The following is a description of a gene set: A process that is carried out at the cellular level which results in the assembly, arrangement of constituent parts, or disassembly of cytoskeletal structures comprising neurofilaments and their associated proteins. species: Mus musculus Mouse Gene Set: GOBP_NEUROFILAMENT_CYTOSKELETON_ORGANIZATION, and this is the list of marker genes: Ndel1, Arhgef28, Cln8, Nefm, Ina, Atp8a2, Nefl, Atf2, Nefh, Vps54, Sod1